Given this list of marker genes Uprt, Shmt1, Nt5c3, Upp1, Upp2, Dhfr, Nme2, Nme1 (NME/NM23 nucleoside diphosphate kinase 1), Dhodh, Cda, Cad, Dpyd, Upb1, Umps, Dut, Dck, Dctd, Tyms, Dpys, Uck1, Nme3, Uck2, Nt5c, Tymp, Uckl1, Nt5m, Shmt2, here is a description of the gene set: species: Mus musculus The chemical reactions and pathways involving pyrimidine nucleoside monophosphate, a compound consisting of a pyrimidine base linked to a ribose or deoxyribose sugar esterified with phosphate on the sugar. Mouse Gene Set: GOBP_PYRIMIDINE_NUCLEOSIDE_MONOPHOSPHATE_METABOLIC_PROCESS